The following is a description of a gene set: Abnormal increase in retinal thickness in the macular area observed on fundoscopy or fundus imaging. Macular thickening Human Gene Set: HP_MACULAR_THICKENING species: Homo sapiens, and this is the list of marker genes: RDH5, CRX, PROM1, ARL6, NF2, CC2D2A, PRPH2, TSPAN12, OAT, CHM, IFT88, RP9, CNGB1, TREX1, RPGRIP1, FAM161A, CTNNB1, APC, RGR, VHL, RPGR, TOPORS, IFT140, HGSNAT, CDHR1, ARL2BP, PDE6G, CLRN1, ZNF513, BBS1, NDP, SCAPER, NRL, MERTK, SNRNP200, BEST1, CA4 (NCBI Gene Id 762), IMPDH1, USH2A, AHR, RP1L1, LRAT, NR2E3, C1QTNF5, NOD2, RP1, LRP5, CYP4V2, DHX38, PRPF3, CRB1, MAK, TULP1, OFD1, FZD4, IFT172, HLA-A, CCND1, IDH3A, KIZ, PDE6B (phosphodiesterase 6B), BBS2, SEMA4A, PCARE, KLHL7, TTC8, PRPF31, SAG, RP2, EYS, RPE65, PRPF8, ABCA4, TRNT1, TUB, IMPG2, RDH12, CFAP418, CERKL, PRPF6, NEK2, GUCA1B, IMPG1, ARL3, SPATA7, NLRP3, ZNF408, FSCN2, AGBL5, ROM1, ARHGEF18 (NCBI Gene Id 85008), MFRP, PRPF4, CNGA1, RHO, POMGNT1, PRCD, RBP3, RLBP1, AHI1 (Abelson helper integration site 1), DHDDS, REEP6, SLC7A14 (NCBI Gene Id 57709), PDE6A, IDH3B, KIAA1549